Given this list of marker genes FUCA2, FUCA1, FUT9, FUT5, FUT8, POFUT1, FUOM, FUT2, POFUT2, FUT7, B3GLCT, FUT1, FPGT, FUT10, FUT4, HSD17B14, FUT6, here is a description of the gene set: The chemical reactions and pathways involving fucose, or 6-deoxygalactose, which has two enantiomers, D-fucose and L-fucose. Human Gene Set: GOBP_FUCOSE_METABOLIC_PROCESS species: Homo sapiens